Given this list of marker genes UQCC1, LIN52, CLK4, LINC00992, ATP13A4, C19orf44, TNFSF9, SP8, SEMA4B, RPS13, PRPF4, SRSF10, CATSPERG, LINC02960, HSPA9, ECE1, EEF1A1P23, MPDU1-AS1 (NCBI Gene Id 102724164), TOMM40, RMND1, NSUN4, UBC, RAD1, CDC25C (NCBI Gene Id 995), NEAT1, AMBRA1, ARMT1, GLOD4, PSMA5, ELMOD3, CDC26 (cell division cycle 26), CALR3, CTDSPL2-DT (NCBI Gene Id 120017340), RETSAT, LASP1, ENSG00000263280, CLDN7, EIF4G2, FEM1B, USPL1, CTDSPL2, ENSG00000246308, MRM3, COPS7A, MPDU1, BRIX1, HIGD2A, SKIC3, CIC, NOP16, HEXIM1, HMGB1, FAM133B, FAM53C, ARSK, here is a description of the gene set: from publication Yevshin I, Sharipov R, Kolmykov S, Kondrakhin Y, Kolpakov F (PMID 30445619) species: Homo sapiens Human Gene Set: IRX3_TARGET_GENES Genes containing one or more binding sites for (IRX3) in their promoter regions (TSS -1000,+100 bp) as identified by GTRD version 20.06 ChIP-seq harmonization.